Given this list of marker genes SGK1, PDPK1, CDK2, RICTOR, YWHAZ, DEPTOR, BRAF, PRKCA, RHEB, CYCS, YWHAG, ULK1, ULK2, RRN3, BNIP3 (BCL2 interacting protein 3), SREBF1, YWHAE, PLD1, MLST8, IKBKB, PDCD4, CLIP1, YWHAQ, MTOR (NCBI Gene Id 2476), RRAGC, CCNE1, YY1, EEF2K (NCBI Gene Id 29904), PML, YWHAB, EIF4E, YWHAH (tyrosine 3-monooxygenase/tryptophan 5-monooxygenase activation protein eta), MAPKAP1, DDIT4, MAPK1, PXN, AKT1, EIF4EBP1, RB1CC1, RRAGD, MAPK3, SFN, PRR5, POLDIP3, TSC1, TSC2, RPTOR, KRAS, PLD2, RRAGB (Ras related GTP binding B), PPARGC1A, SSPOP, RPS6KA1, RAF1, ATG13, RPS6KB1, RRAGA, HRAS, RAC1, EIF4B, EEF2, EIF4A1, MAP2K2, RHOA, FBXW11, AKT1S1, IRS1, MAP2K1, NRAS, here is a description of the gene set: Human Gene Set: PID_MTOR_4PATHWAY species: Homo sapiens from publication Schaefer CF, Anthony K, Krupa S, Buchoff J, Day M, Hannay T, Buetow KH (PMID 18832364) mTOR signaling pathway